Given this list of marker genes PPP1R12B, PPCDC, MEFV, PRELID3A, KCNJ15, ANGPTL7, SOCS7, HCAR3, STK3, NPL, WAS, TMEM35A, FCAR, CPPED1, PTGS2, HEY1, KCTD15, LINC00652, MPPE1, ATP6V1B2 (NCBI Gene Id 526), TLR6, AQP9, TNFAIP2, DRAM1 (NCBI Gene Id 55332), CDK19, ENDOU, PDK3, SSH3, MYCBP, STAM2, SDCBP, VNN3P, CSF3R, APH1B, KRT19P2, DPEP3, TTC39A, GALNT14, STON1, CLCN4, FAR2, STX3, SLC39A2, RUBCNL, DCSTAMP, ZNF816, FOXA1, CYB5R4, AFM, DGKG, PI15, ABHD5, NCOA4, MPZL1, RORB, TREM1, EPHB1, ZNF185, BAMBI, SEMA3C, TNS1, CD82, KCNJ2, FCGR2A, MME, TNFRSF10C, PTGS1, BCL6, TGFA, NFE2, H2AC6, DDX4 (DEAD-box helicase 4), MUSK, MSRB1, GCA, TFEB, BRINP1, RAPGEF5, BCL2A1, LHFPL6, CHRDL1, H4C8, GK, TOR4A, USP10, DENND3, SIGLEC5, GK3, GUCY1A2, KLF1, MNDA, CHST4, MTAP, SLC22A4, DHRS9, IL1B, UPB1, QPCT, SERHL2 (NCBI Gene Id 253190), C5AR2, IMPA2, ADGRG3, ARHGEF15 (Rho guanine nucleotide exchange factor 15), LMBRD1, ST6GALNAC2, LITAF, SNAP91, EGFR (epidermal growth factor receptor), ADGRE3, H1-2, TALDO1, SMIM14, ADM, DYRK3, AATK, F2RL1, TREML2, TLR8, FAM163A, MTARC1, LIMK2, GNG10, ECHDC3, S100A12, PHC2 (polyhomeotic homolog 2), SLC7A11, RALB, NR5A2, ANXA13, LY96, IFIT1, CREB5, ST20, ARAP3, MAK, RGS4, TLR4, TUFT1 (NCBI Gene Id 7286), NUP214, SORD, LTBR, IFNGR1, GAL, TACR3, P2RY2 (NCBI Gene Id 5029), SLPI, KRT84, KCNK1 (NCBI Gene Id 3775), SOD2, ANGPTL2, SLITRK2, IFNGR2, HSD3B2, FGF2, P2RY13, S100P, ARPC5, CCL23, CXCR2, CNGA3, DDN, ITIH5, NRN1, SASH1, ABCG5, MEGF9, PRKD1, IFIT3, CTBS, HTR3B, CXCL1, GPR63, BST1, CALCA, LAMP5, CLEC4E (NCBI Gene Id 26253), GABARAP, NPY4R, CHP2, CCDC170, XKR8, CLEC4A, CDK14, VNN2, PLBD1 (NCBI Gene Id 79887), ZNF552, LHX6, APOBEC3A, IGSF6, PRUNE2 (NCBI Gene Id 23273), RNF141, RGN, CEACAM1, CXCR1, IMPDH1, DDR1-DT, HAL, CCL8, MED25, here is a description of the gene set: from publication Abbas AR, Baldwin D, Ma Y, Ouyang W, Gurney A, Martin F, Fong S, van Lookeren Campagne M, Godowski P, Williams PM, Chan AC, Clark HF (PMID 15789058) studied in species Homo sapiens Human Gene Set: GSE22886_NAIVE_TCELL_VS_NEUTROPHIL_DN Immune cell-specific expression is one indication of the importance of a gene's role in the immune response. In order to identify such patterns, we set out to broadly profile gene expression in a variety of immune cells. Genes down-regulated in comparison of naive CD4 CD8 T cells versus unstimulated neutrophils.